The following is a description of a gene set: studied in species Homo sapiens Human Gene Set: GOBP_POSITIVE_REGULATION_OF_PROTEIN_LOCALIZATION_TO_CHROMOSOME_TELOMERIC_REGION Any process that activates or increases the frequency, rate or extent of protein localization to chromosome, telomeric region., and this is the list of marker genes: GNL3, PML, GNL3L, TCP1, WRAP53, CCT6A